Given this list of marker genes CDK6, CCNE2, RB1, CDK2, CDKN1B, E2F2, CCND3, CDKN1A, CCNE1, E2F3, CCND2, TFDP2, TFDP1, CCND1, E2F1, CDKN1C, CDK4, here is a description of the gene set: Human Gene Set: REACTOME_ABERRANT_REGULATION_OF_MITOTIC_G1_S_TRANSITION_IN_CANCER_DUE_TO_RB1_DEFECTS Aberrant regulation of mitotic G1/S transition in cancer due to RB1 defects studied in species Homo sapiens